Given this list of marker genes CDO1, SELENOP, ATOX1, GPX1, PRDX6, CAT, NUDT1, SOD1, PDLIM1, SDS, GPX3, GPX4, GOT1, DUSP1, MPO, GPX2, here is a description of the gene set: studied in species Homo sapiens ROS (glutathione, ox stress). Human Gene Set: MODULE_530